Given this list of marker genes FCGR2B, MEX3C, ADK, ERRFI1, GNA13, TXK, MFSD6, NDUFA4, SCML4, LATS2, GRAMD4, RNF145, GPR183, LDLRAP1, GRAMD1B, ARHGAP5, PPP1R14B, RASA3, POU2F2, HDAC10, GZMM, SLC7A1, TBXA2R, RAP1GAP2, MSANTD5, S1PR1, PLXNC1, SIDT1, CD55, MAP4K4, CD2AP, IL6ST, RNF144A, CYP17A1, SLAMF6, ZBTB2, RCSD1, C19orf38, GPR55, CXCR4, IQGAP2, KLF2, ACOT2, KLF3, RAPGEF4, DZIP1, CD9, USP28, BZW2, TBC1D22B, SELL, RAB42, DNAJC27, NT5DC3, BACH2, PRKAB2, PATJ, SSH2, NR4A1, KLK13, PRKCB, RABGGTA, CPM, RRP12, AHR, KIF23, LPIN1, TINAG, SPRED2, FOXP1, MDN1, SOCS3, ENC1, TNFSF8, CD44, TCEA2, CBX8, RNF138, METTL27, KBTBD11, PDE1B, SAMD3, MAD2L2, GPR63, ZBTB40, LRRC10, PLEKHG2 (pleckstrin homology and RhoGEF domain containing G2), PDLIM1, BIN2, BTLA, TNKS1BP1, BCL2L11, IL2, S1PR5, NEDD4L, JAK1, IQSEC1, CD27, PDE2A, ABTB3 (NCBI Gene Id 440109), HS3ST3B1, NSG2, USP12, KLF4, CD7, P2RY10, FRYL, OTUD1, MBOAT1, MBP, S1PR4, PDE8A, SMAD7, ATP2B1, NETO1, SH3BP5, TSPAN5, RFLNB, SMAD3 (SMAD family member 3), BRPF3, CRIM1, TUBB4B, SLC17A9 (solute carrier family 17 member 9), TCF20, AGPAT3, RASGRP2, ZSWIM6, PIK3R1, WSB1, GPD1L, DAPL1, COBLL1, CMAHP, CXXC1, SMPDL3B, IL6R, AS3MT, TTC7B, MYB, CNR2, CCR7, CX3CR1, TRIB2, ETS1, RIPOR2, ATP11B, DMRTA1, CD40LG, EMB, AMD1, TCF7, NLE1, CYRIA, NCK2, RXRA, GPR155, LEF1, SGTB (small glutamine rich tetratricopeptide repeat co-chaperone beta), KIF1B, ORAI3, ACSF2 (NCBI Gene Id 80221), PIK3R5, CPEB2, DGKH, RUNDC3B, SLC11A2, KLRG1, USP33, VAV3, DGKA, CCND3, KATNB1, FGF13, WDR4, here is a description of the gene set: This study aims at identifying genes that are NIK/NF-kappaB2 responsive in murine dendritic cells matured in vivo. from publication Lind EF, Ahonen CL, Wasiuk A, Kosaka Y, Becher B, Bennett KA, Noelle RJ (PMID 18566401) studied in species Homo sapiens Human Gene Set: GSE7219_UNSTIM_VS_LPS_AND_ANTI_CD40_STIM_DC_UP Genes up-regulated in dendric cells: untreated versus LPS and anti-CD40.